Given this list of marker genes IVNS1ABP, CD1D, COL1A1, MAOB, ATP8A1, ING3, NEMF, CNOT7, TSHZ1, TCF7L2, CELF1, FERMT2, SH3D19, NAB1, EPHA3, MAGT1, CCNT2, RBM28, SEC24B, CUBN, ABCF2, SP4, RANGAP1 (NCBI Gene Id 6381), AGAP3, PPP4R1, RNF2, WBP1L, NCL, ALCAM, NUDT4, PPP6R1 (protein phosphatase 6 regulatory subunit 1), NAA50, FEM1B, RBP4, NUCKS1, CLCN5, MMP14, MEF2A, FKRP, POSTN, ANKRD28, PLXNB2, AGPS, CSNK1G3, GULOP, CTDSP2, SPIN1, ACO1, SNX5, LEMD3, FAM168B, CSF1R, APOM, BNC1, ANGPTL2, HIPK3, F2R, MTMR4 (myotubularin related protein 4), BUB1, SHROOM3, CASP9, UMPS, SCARF2, VCAM1, CLIC1, KCTD20, PTPRG, MED16, ODF2, PJA2 (praja ring finger ubiquitin ligase 2), CEPT1 (NCBI Gene Id 10390), LRRC58, TCF21, PHETA1, SPART (NCBI Gene Id 23111), COX15, GATA6, UBQLN4 (NCBI Gene Id 56893), ETS1, TPR (NCBI Gene Id 7175), WNT5A, ERBIN, EPB41L3, CTTN, TENT5C (NCBI Gene Id 54855), AKAP10, XIAP, HEMGN, ABCG2, SMARCA5, DGCR8, TIA1, ZNF148, PRPF6, RCBTB2, GRB10, SSR1, RAB22A, FYTTD1, PPIG, CUL3, KAT2B, CTTNBP2NL, KIF11, ZFPM1, UBL7, PSAP, GLI3, MARK2, SPAG5 (sperm associated antigen 5), SRSF1, PCYT1A, TCF4, PAPOLA, IGFBP1, SNW1, ABCF1, SH3GLB1, PLAGL1, OTUD4, STK3, IRF2BPL, CA2, STAMBP, BASP1, MATR3 (matrin 3), COL1A2, EPRS1, ATIC, DHX29, PMPCA, PRPF19, KLF3, MBD1, UTP3, MAP1B, PTEN, CHP1, CSNK1D, NFYC, PDGFRA, UTRN, HNRNPA1L2, ABCB7, KIF15, FUBP1, ACTR1B, RO60, YKT6, AMBP, HMOX1, ZMYND11 (NCBI Gene Id 10771), DPYSL3, CERT1, MAPRE1, TBKBP1, PPM1B, HDLBP, PANK3, SLC4A1, TMX4, PPHLN1, CDC27, DACT3, ZNF22, NUP205, GTF3C2, DGCR2, ZBTB12, SELENOI, TGFBR1, ATRX, PITX2, ERMAP, MAF, TRPC4AP, CA7, ALAS2, CBX2, CAD, PITPNB, LPAR1, HNRNPH3, EFHD2, RAB7A, RSRC2, PNISR, USP22, SATB1, TBX3, TTR (transthyretin), FOXM1, OGFRL1, CYTH3, TWSG1, LMO4, UFD1, CNOT11, GHR, CAPN6, MLLT10, KANK2, ARF3, APOB (apolipoprotein B), RHAG, USP48, SAFB2 (NCBI Gene Id 9667), RCBTB1, PKNOX1, AGO2, CCAR1, TGOLN2, NHLH2, TNPO3, ZNF830, MTDH, DCN, RFK, ANP32E, SLC39A8, ARID4B, CILK1, GAL3ST4, PAFAH1B2, PLXNA2, FGB, BTBD2, SEC62, SREK1, RNF220, TBRG4, MACO1, KIN, INCENP, COL5A2, SMC1A, SLC25A13, ANGPT1, SRPRA, EIF4G1, YWHAG, LRRC59, SKIC2, SLC12A7, POLE3, ARPC1B, FGFR2, ALG2, BCL11A, CLPX, SMAD3, HAND2, ASB4, FOXP1, ARHGAP5, FZD1, BCLAF1, CBL, DHX9, MBNL2, GATA4, MAPK1IP1L, SLC39A10, SLC25A46, TLL1, PIK3R1, TBL3 (NCBI Gene Id 10607), ELL2, UBXN4, METTL16, ISG20L2, ATF7IP, PRRX1, EIF5B, ATXN2, DNAJC7, AP1G1, DUSP18, SCYL2, THAP11, TGIF2, TNFAIP1, AMN, TBX2, MLLT1, SHC1, LASP1, PPFIA1, CKAP4, STAU1, GPS2, CAND1, RPS6KB1, POFUT2, EPHA4, PBX3, PHF20L1, ST13, SSR3, PRKAR2A, GTF2F1, ATXN7L3B, EDEM1, TMEM248, ZCCHC14 (NCBI Gene Id 84995), MKNK2, NNAT, SON, USP16, FZD5, CNOT6L, SLC16A13, MIA3, CTSC, FBXW8, SPHKAP, ENSA, DDX18, GRAMD2B, PRKCI, UPK3B, YTHDF3, GLYR1, SLC13A4, SERPINF2, NRAS, FGA, RNF20, THRAP3, SEPTIN1, COP1, COL9A1, TMEM33, SGPL1, NONO, PRC1, POGK, MARCHF7, TBC1D2B, DTL (denticleless E3 ubiquitin protein ligase homolog), ZNF267, SUZ12, SOX4, BAG6, UFM1, ATP2B1 (NCBI Gene Id 490), FADS2 (NCBI Gene Id 9415), DDX21, APOE, ZFX, PRPF38B, SNX1, POLR3C, CNTRL, LYPLA1, HEXIM1, ACTR2, SSBP4, DACT1, NRK (Nik related kinase), HUS1, PDIA6, PGM5, S1PR3, GANAB, UGCG, ARB2A, ALB, PCBP4, SFPQ, MYB, MECOM, PRKAR2B, TIRAP, SGO2, SEC23A, DBT, MDM4, SMC6, SLC38A2, ZFP36L2, PLPP3, LIN7C, OLFM1, FGG, PCTP, RTF1, CCSER2, HCFC1, EXOC5, TBX15, OVCA2, ADAM10, NORAD, ACP1, EPB41L2, RWDD4, TPM4, DDX17, PRPF40A, PIM1, ROCK2, RBM25, PDZK1, FAM32A, ADPRS, UBAP2, ARNT, ARL8B, SFSWAP, RMND5A, FBXW11, TFRC, CWF19L1, USP19, MAB21L2, ZNF260, POLA1, NR2F1 (nuclear receptor subfamily 2 group F member 1), FLRT3, GPBP1, LHX9, KNOP1, EFNB3, HMGCR, LPL, ITIH2, SLC44A1, SLC2A2, MSL1 (NCBI Gene Id 339287), IGDCC3, QKI, DPF3, IL6ST, CSF2RB, RNF38, CITED4, TNC, PELI1, FAF1, BAZ1B, CLIP3, TIMP2, ADD3, WDR26, ATP11C, ZFAND5, BDNF, VCL, RBFOX2, UTP15 (NCBI Gene Id 84135), GNG2, CDH2, ACP5, ANAPC5, SUPT16H, SHOX2, TBL1X, APOA4, TRAK2, HP1BP3, BRD8, GNAI3, CAGE1 (cancer antigen 1), GNA12, KIF1B, RCC2, AK3, MEN1, LPP, ZNF106 (NCBI Gene Id 64397), MT-CYB, ENAH, CBX5, TMPRSS2, PARD6B (NCBI Gene Id 84612), GUCY1A1, APOA1, STARD4, RBM5, MTUS2, KPNA3, RCOR3, NOLC1, CSTF3, SEC63, NCK2, FOXF1, ZNF143, HMG20B, ST3GAL5, SH3BP5, LCP1, EPM2AIP1, LIX1L, ILRUN, SLC31A2, SNX2, EFNA5, PLN, PLVAP, HSD11B2, ZKSCAN1, RBBP9, TMEM64, ZNF146, SERPINA1, HACD3, ZNF574 (NCBI Gene Id 64763), MAPKAPK2, AMD1, RAB10, RELN, NFATC3, PLG, NUFIP2, here is a description of the gene set: studied in species Mus musculus from publication Martoriati A, Doumont G, Alcalay M, Bellefroid E, Pelicci PG, Marine JC (PMID 15608685) Genes down-regulated in non-apoptotic tissues (fetal liver) after MDM4 knockout. The p53 tumour suppressor functions as a transcriptional activator, and several p53-inducible genes that play a critical proapoptotic role have been described. Moreover, p53 regulates the expression of various proteins participating in autoregulatory feedback loops, including proteins that negatively control p53 stability (Mdm2 and Pirh2) or modulate stress-induced phosphorylation of p53 on Ser-46 (p53DINP1 or Wip1), a key event for p53-induced apoptosis. Here, we describe a new systematic analysis of p53 targets using oligonucleotide chips, and report the identification of dapk1 as a novel p53 target. We demonstrate that dapk1 mRNA levels increase in a p53-dependent manner in various cellular settings. Both human and mouse dapk1 genomic loci contain DNA sequences that bind p53 in vitro and in vivo. Since dapk1 encodes a serine/threonine kinase previously shown to suppress oncogene-induced transformation by activating a p19ARF/p53-dependent apoptotic checkpoint, our results suggest that Dapk1 participates in a new positive feedback loop controlling p53 activation and apoptosis. Human Gene Set: MARTORIATI_MDM4_TARGETS_FETAL_LIVER_DN